The following is a description of a gene set: Human Gene Set: REACTOME_CLASS_B_2_SECRETIN_FAMILY_RECEPTORS species: Homo sapiens Class B/2 (Secretin family receptors), and this is the list of marker genes: GNG11, GNG8, WNT7A, ADM, PTCH1, CALCR, CRH, WNT5A, GCGR, VIPR1, UCN, FZD6, RAMP1, GNB4, GNG4, VIPR2, CD55, GCG, WNT16, GNG2, CRHR2, GNG10, WNT3A, DHH, CRHR1, FZD5, FZD8, ADCYAP1, GIP (NCBI Gene Id 2695), GNG5 (NCBI Gene Id 2787), PTH2, ADGRE1, GIPR, SCTR, ADGRE2, SHH, SMO, PTH, GNAS, WNT8A, GNB2, WNT10B, GHRH, PTHLH, GNGT2, GLP2R, CALCB, GNG12, GNG7, ADGRE5, SCT, GNGT1, WNT8B, WNT3, GLP1R, CALCA, IHH, WNT10A, WNT11, WNT2, CRHBP, ADGRE3, GNG13, FZD10, FZD7, PTH2R, WNT1, GHRHR, UCN3, VIP, WNT4 (Wnt family member 4), WNT2B, GNB3, FZD2, GNB5, RAMP2, UCN2, RAMP3, WNT9A, GNG3, ADCYAP1R1, WNT6, PTCH2, IAPP (NCBI Gene Id 3375), FZD1, FZD3, GNB1, WNT9B, FZD9, ADM2, WNT7B, CALCRL, FZD4, PTH1R